The following is a description of a gene set: Human Gene Set: IVANOVA_HEMATOPOIESIS_STEM_CELL_AND_PROGENITOR from publication Ivanova NB, Dimos JT, Schaniel C, Hackney JA, Moore KA, Lemischka IR (PMID 12228721) species: Mus musculus Genes in the expression cluster 'HSC and Progenitors Shared': up-regulated in hematopoietic stem cells (HSC) and progenitors from adult bone marrow and fetal liver. Mechanisms regulating self-renewal and cell fate decisions in mammalian stem cells are poorly understood. We determined global gene expression profiles for mouse and human hematopoietic stem cells and other stages of the hematopoietic hierarchy. Murine and human hematopoietic stem cells share a number of expressed gene products, which define key conserved regulatory pathways in this developmental system. Moreover, in the mouse, a portion of the genetic program of hematopoietic stem cells is shared with embryonic and neural stem cells. This overlapping set of gene products represents a molecular signature of stem cells., and this is the list of marker genes: MAP1S, DNMT3B, KAT2A, ARMCX2, ZMIZ1, MPRIP, KCNMB1, LHPP, RHOBTB1 (NCBI Gene Id 9886), HSPA4, DNAJB9, CLEC14A, IRF2BPL, HSPA1L, GNAZ, C2CD2, ITGB4, NELL1, GMPPB, IVNS1ABP, BPHL, KIT, NDN, FUT8 (fucosyltransferase 8), MMP23B, MYLK, BAZ1B, MTMR10, RUNX2, MEIS1 (Meis homeobox 1), SMAD5, MUC1, TMEM135, MAN2A2, NOP58, ARHGEF17, DENND2D (DENN domain containing 2D), GTF3C6, F2RL3 (NCBI Gene Id 9002), UBASH3B, CWF19L1, SH3PXD2B, ATF6B, SPOCK2, LRATD2, SLC7A6, TSKS, FAM43A, INSR (NCBI Gene Id 3643), NIPSNAP1 (nipsnap homolog 1), TMEM176B, NAV1, TYMP, ADGRL4, PRKCE, TAMALIN, FZD8, LGALS3BP, FNBP4, CYSLTR1, ZBTB38 (zinc finger and BTB domain containing 38), CALR, SPACA9, GLYCAM1, CLDN8, IL11RA, GPR15LG, RET, ELOVL6, CSRNP1, CCDC90B, GOPC, RHOBTB3, MTF2, SEPTIN1, PCDH7, HIC2, TAF4B, SNX30, TMSB10, NAA25 (N-alpha-acetyltransferase 25, NatB auxiliary subunit), GNAS-AS1, DNAJC2, TTC9, USP30, ALDH5A1, MAPK6, CCDC85B, EPB41L4B, SIAE, HS1BP3, HUWE1, PITPNM2, QSOX1 (quiescin sulfhydryl oxidase 1), AGO1, BCL2L14, DUSP12 (dual specificity phosphatase 12), TEK, WDR19, ZCCHC3, STXBP1, KLF4, GCAT, FLT3, ABCC1, MGAT3, BYSL, ZNF260, GSTK1, RAB38, NLRP4, MIR191, PLAC9, MDGA1, KAZN, ABCF2, IRAK1, PRR5 (proline rich 5), RASSF2, HNRNPU, SPMIP10, TES, CCAR1, WNT6, EDIL3, KIFBP, KIFAP3, RS1 (retinoschisin 1), UBA52, PLSCR1, MIGA1, FABP9, NEK6, TP53RK, MN1, DLL1, ATXN3, YLPM1, MIPOL1, KLF12, SIGIRR (NCBI Gene Id 59307), TMEM106C, PLEKHF1, HP1BP3, ARPP19, DHDH, SCN8A, SYTL4, RALGAPB, MEF2C, PEX1, KRBA1, TTC27, TAF1D, GSTM5, GZMH (NCBI Gene Id 90562), TCTN1, CTBP2, OCRL, CEND1, PGM1, MIDN, GRP, ZNF22, HLA-B, APOA5, HDHD5, ZNF629, BOD1, FAAP20, PDCD6IP, ARHGAP35, MIER2, DISP1, AMER1, SMAD9, ARL3, TACR2, ZNF827, GJA1, SLC5A6, RBPMS, ARHGEF2, PLPPR3, CLASRP, KIAA1671, IPO4, TMTC2, SLC35F2, ARHGAP32 (Rho GTPase activating protein 32), ZNF704, RWDD3 (RWD domain containing 3), GALNT11, PPIL4 (NCBI Gene Id 92943), ABCB11, PEMT, FGD5, PCP4L1, ART1, SMARCC1 (SWI/SNF related, matrix associated, actin dependent regulator of chromatin subfamily c member 1), LRRC58, INO80E, C1orf21, CHCHD6, PRRC2C, C3orf33, PTPRM, RAB37, CA13, NTRK3, PLEKHA3, SFR1, CRACD, POMGNT2, AVEN, SHFL, MBTD1 (mbt domain containing 1), ZBTB10, MTOR, NKAIN1, USP40, PTGDS, IL12RB1, FGF10, NCAM2, KCNC1, ASRGL1, FLNB, MUS81, ACADL, BRF2, MRPL19, SLA2, VEGFB, LGI4, ARMH3, CAPSL (NCBI Gene Id 133690), FASN, CDK9, IGF2BP1, CD93, ASCL1, GEMIN5, PTPN20, ASAH2, CNOT1, ECPAS, KCND3 (NCBI Gene Id 3752), ZNF326, PGRMC1, PHC1, DAPK1, ZNF787, EPRS1, SLC43A2, IFT46, THSD1, SMS, MLLT6, GUCA1B, YJU2, CLIP4 (CAP-Gly domain containing linker protein family member 4), NRG4, TTC21B, PSKH1, SPART, RNF138, QSER1, FNBP1L, RNF217, TLE6, ACAD9, BSN, GABPA, NKAPD1 (NKAP domain containing 1), TAOK3, PIK3IP1, FGF18, BEND4, MXD4, KANK2, GIMAP6, CREM, LINGO3, CASP8, TNNI1, SH2B3, GULP1, ADA, DAGLA, TMEM201, ETV6, FCHSD2, SOX4, ESAM, PAFAH2, EXOC3L2, IFT56, POGK, FBLN2 (fibulin 2), DEPTOR, PGPEP1, CPEB1, EPYC, DLG3, TTPA, KCTD1, CLCA2, MAMDC2, CARMIL2, FIRRE, RAPGEF5 (NCBI Gene Id 9771), BTC, GPR62, TP53I11, RNF152, LIMD2, RRP1B, NPL, AVPI1, TLE4, SERPINF1, FADS2 (NCBI Gene Id 9415), INTS12, SLC39A6, RPUSD4, SH2B1, SESTD1, GPX5, ABL1, ZNF503, PRTG, DAG1, FZD6, USH2A, EGLN3, USP28, CYP4V2, C21orf91, POC5, LIX1L, KIAA1549, FBXL19, ZNF136, CCND2, ITGA6, KCNJ14, RAB26, SYT11, PDRG1, TAMM41, STOX2, DDX11, SLC50A1, FBXO21, NSG1, CNRIP1, OSBPL3, TFPI, FKBP3, MCCC1, SMIM11, CORO2A, BFAR (bifunctional apoptosis regulator), HES2, KLHL3, RBBP9, EFNA1, RHBDD2, SEMA5B, BCL2 (BCL2 apoptosis regulator), SYDE2, TNFSF10, FSTL5 (follistatin like 5), RLIM, RPS25, ACTR3B, CCDC93, ANKRD37, NORAD, AP5Z1, MED11, KRT10, ARMC10, FOXB1, COA7, ACSF3, CEBPZ, TERF2, KRT18, RCN2, HMGA2, SOD2, TBC1D16, FKBP1A, NPPC, SMAD1, WNT11, PTPRCAP, NUFIP1, NAP1L3, GPN1, FBXW12, MLXIPL, PEAK1, KHDRBS3, PLEKHA5, HTR2A, CFAP54, PAIP2B, PLPPR2, PARM1, NCS1, USP2, PTX4, PCED1A, XXYLT1, SYNGR1, DVL3, GPRASP2, EARS2, C4A, ZMYM4, CSN1S2AP, ACAD8 (acyl-CoA dehydrogenase family member 8, NCBI Gene Id 27034), DCBLD1, ENTREP3, HINT2, NT5C3B, MPPED2, ACSM1, KREMEN1, HOXA6, TCEA2, MSI2, NRGN, MAGI2, GATA2, NALF1, LRRC1, AKAP6 (A-kinase anchoring protein 6), CBFA2T2, MICAL2, KDELR1, ZXDB (zinc finger X-linked duplicated B), PCMTD1, MLEC, ZNF521, VWA8 (NCBI Gene Id 23078), LTBR, HOXA4, EVA1B, GARIN5A, MYCN, SNORD8, SLC1A1, PER2, ACOT2, PDCD4, NWD2, HIC1, AKR1B10, PRKCH, IFT22, SPMIP6, ANXA10, PHPT1, SLC4A8, DIP2C, NAXE, LATS2, CAND2, PPIC, HMGN5, ARHGEF5, TPK1, MEAF6, SYDE1, SLC25A36, SPRED1, CEP170B, PTPDC1, ADGRG1, USHBP1, ABI2, CD27, CEACAM4, TGIF1 (TGFB induced factor homeobox 1), ENDOU, MFNG, SLC4A1AP, UQCC1, MPL, ERGIC1, CBFA2T3, DUSP7, SMYD5, HOXA9, L3HYPDH (trans-L-3-hydroxyproline dehydratase), CIBAR1, TTC22, SARAF, PKP4, PLXDC2, PRDM5, TNFAIP8L1, AMIGO2 (NCBI Gene Id 347902), C8orf58 (chromosome 8 open reading frame 58), BNIP5, SLC17A5, ARL5B, SLC12A7, DICER1, TCERG1L (transcription elongation regulator 1 like), PNPLA6, CRTC1, ILDR2, AFAP1L1 (NCBI Gene Id 134265), EID2, EN2, SUFU, TNIK, ENAH, PHF3, HMOX2, SNAPC1, DNAJC1, STAMBP, PRSS8, PTOV1, SMO, VTA1, REPIN1, ZPBP, HEPHL1, RBMY1F, TRIM32, GLIS2, ITPR1, NOXO1, CAMK2A, RMND1, ZNF12, DHTKD1, ADRB3, ABCB1, GIMAP5, PRSS12, ALKBH6, NOP14, WDR72, FBXW11, ITGB8, HSD3B7, GADD45B, ISLR2, LDHD, POU2F2, UBE2E2